Given this list of marker genes OVOL2, PAX6, FOXE3, PITX2, FOXC1 (forkhead box C1), CYP1B1, here is a description of the gene set: studied in species Homo sapiens Human Gene Set: HP_THINNING_OF_DESCEMET_MEMBRANE A reduction in the thickness of Descemet's membrane. Thinning of Descemet membrane